Given this list of marker genes TERF2, RAD50, ANKLE1, ERCC2, ZSCAN4 (zinc finger and SCAN domain containing 4), MRE11, MLH1 (NCBI Gene Id 4292), here is a description of the gene set: studied in species Homo sapiens Human Gene Set: GOBP_REGULATION_OF_MITOTIC_RECOMBINATION Any process that modulates the frequency, rate or extent of DNA recombination during mitosis.